The following is a description of a gene set: studied in species Mus musculus Catalysis of the reaction: adenosine + H2O = inosine + NH3. Mouse Gene Set: GOMF_ADENOSINE_DEAMINASE_ACTIVITY, and this is the list of marker genes: Adad1, Lacc1, Adal, Adarb2, Adat1, Adad2, Adat2, Adarb1, Adat3, Ada, Adar